Given this list of marker genes Srf, Pik3cb, Irs4, Map3k6, Ppp1ccb, Akt2, Socs1, Map2k2, Mapk3, Gys2, Mtor, Shc1, Mapk4 (mitogen-activated protein kinase 4), Map3k8, Map2k7, Mapk10, Vamp2, Arf1, Map4k3, Myo1c, Mapk8, Cbl, Trib3, Sos1, Arf6, Prkaa1, Map4k2, Prkca, Snap23, Cblc, Sos2 (SOS Ras/Rho guanine nucleotide exchange factor 2), Map2k1, Eif4ebp1, Sgk3, Map3k3, Pdpk1, Stxbp1, Rhoq, Map4k4, Rab4a (RAB4A, member RAS oncogene family), Rps6kb2, Ppp1cc, Map3k4, Map3k10, Xbp1, Rhoj, Pik3r3, Sgk2, Mapk9, Gab1, Gsk3b, Pik3r2, Rps6kb1, Rac2, Akt1, Ehd2, Ikbkb, Elk1, Cblb, Stxbp4, Grb10, Foxo3 (forkhead box O3), Irs1, Map2k3, Pfkm, Prkci, Mapk1, Pik3cg, Rac1, Shc2, Cap1, Map3k14, Map2k6, Pik3c2g, Sh2b2, Pik3cd, Lipe (NCBI Gene Id 71060), Ptpn11, Flot2, Kif3a, Hras, Slc2a4, Mapk7, Rps6ka1, Stxbp3, Map2k4, Tsc2, Ptpn1, Crk, Prkaa2, Mink1 (NCBI Gene Id 50932), Rps6ka6, Slc2a1, Ptprf, Map3k12, Pik3c2a, Prkcd, Ehd1, Stx4a, Map3k11, Arhgap33, Insr, Raf1, Sorbs1, Map4k1, Irs3, Rps6ka5, Kif5b, Pik3r4, Stxbp2, Mapk6, Inppl1, Map3k13, Tbc1d4, Map3k2, Prkcq, Pik3r1, Jun, Snap25, Socs3, Mapk14, Rps6ka2, Map3k7, Map3k1, Egr1, Cyth3 (cytohesin 3), Prkcz, Grb14, Rapgef1, Pfkl, Prkch, Gyg1, Enpp1, Grb2, Rps6ka4, Mapk11, Gys1, Mapk12, Pik3ca, Map3k9, Inpp4a, Rps6ka3, Igf1r, Eif4e, Fos, Prkcb, Foxo1, Tsc1, Pik3c3, Sgk1, Shc3, Pten, Flot1, Rheb, Map2k5, Map4k5, Rrad, Mapk13, Map3k5, here is a description of the gene set: Mouse Gene Set: WP_INSULIN_SIGNALING species: Mus musculus Insulin signaling